The following is a description of a gene set: Oxidized phospholipids are thought to promote atherogenesis by stimulating endothelial cells (ECs) to produce inflammatory cytokines, such as IL-8. In studies with mouse models, we previously demonstrated that genetic variation in inflammatory responses of endothelial cells to oxidized lipids contributes importantly to atherosclerosis susceptibility. We now show that similar variations occur in cultured aortic ECs derived from multiple heart transplant donors. These variations were stably maintained between passages and, thus, reflect either genetic or epigenetic regulatory differences. Expression array analysis of aortic EC cultures derived from 12 individuals revealed that >genes were regulated by oxidized phospholipids. We have used the observed variations in the sampled population to construct a gene coexpression network comprised of 15 modules of highly connected genes. We show that several identified modules are significantly enriched in genes for known pathways and confirm a module enriched for unfolded protein response (UPR) genes using siRNA and the UPR inducer tunicamycin. On the basis of the constructed network, we predicted that a gene of unknown function (MGC4504) present in the UPR module is a target for UPR transcriptional activator ATF4. Our data also indicate that IL-8 is present in the UPR module and is regulated, in part, by the UPR. We validate these by using siRNA. In conclusion, we show that interindividual variability can be used to group genes into pathways and predict gene-gene regulatory relationships, thus identifying targets potentially involved in susceptibility to common diseases such as atherosclerosis. from publication Gargalovic PS, Imura M, Zhang B, Gharavi NM, Clark MJ, Pagnon J, Yang WP, He A, Truong A, Patel S, Nelson SF, Horvath S, Berliner JA, Kirchgessner TG, Lusis AJ (PMID 16912112) Human Gene Set: GARGALOVIC_RESPONSE_TO_OXIDIZED_PHOSPHOLIPIDS_BLACK_DN species: Homo sapiens Genes from the black module which are dn-regulated in HAEC cells (primary aortic endothelium) after exposure to the oxidized 1-palmitoyl-2-arachidonyl-sn-3-glycerophosphorylcholine (oxPAPC)., and this is the list of marker genes: MTSS1, ZEB2, ABHD10, TARS2 (threonyl-tRNA synthetase 2, mitochondrial), SLC30A1, PIK3C2B, SMAD3, ZNF22, ELAC1 (NCBI Gene Id 55520), LRATD2, OSGEPL1